The following is a description of a gene set: Any process that modulates the frequency, rate or extent of spontaneous synaptic transmission. Mouse Gene Set: GOBP_REGULATION_OF_SPONTANEOUS_SYNAPTIC_TRANSMISSION studied in species Mus musculus, and this is the list of marker genes: App (NCBI Gene Id 319425), Prkn, Slc12a2, Ager, Ppp1r9a, Stx1b (syntaxin 1B), Itgb1